The following is a description of a gene set: part of: Adipogenesis Brown and beige adipocytes convert chemical energy produced by the oxidation of fatty acids and glucose into heat, which is important for thermoregulation and control of body weight. Brown and beige adipocytes largely share the transcription program involved in adaptive non-shivering thermogenesis but develop from different lineages. Brown adipocytes share their precursor cells with skeletal muscle cells and develop in discrete, homogeneous brown adipose tissue depots. Beige adipocytes share their precursor cells with white adipocytes and develop in white adipose tissue in response to environmental stimuli, mainly exposure to cold, with an ability to revert to a white adipocyte-like phenotype. Development of beige adipocytes in white adipose tissue is known as white adipose tissue browning.<br><br>Brown and beige adipocytes have been characterized in most detail in rodents. In humans, brown adipose tissue was thought to regress after infancy, but was shown by multiple studies published after 2007 to persist in substantial deposits into adulthood adulthood. Molecular profiles that correspond to both brown and beige rodent adipocytes have been identified in human brown-designated adipose tissue, and therefore both brown and beige adipocytes are now thought to be conserved in humans.<br><br>The major protein marker of brown and beige adipocytes is Uncoupling protein 1 (UCP1). UCP1 resides at the inner mitochondrial membrane where it translocates protons (H+) from the intermembrane space into the mitochondrial matrix. UCP1 thus dissipates the proton-motive force to be used by ATP synthase, converting the energy released by the respiratory chain into heat. Brown adipose tissue is innervated by the sympathetic nervous system. Noradrenaline is secreted by sympathetic neurons when the central nervous system senses cold. Brown adipocytes possess adrenergic receptors on their surface that are activated by noradrenaline. Activated adrenergic receptors trigger a signaling cascade that induces lipolysis and activates UCP1.<br><br>Multiple transcription factors that regulate the thermogenic molecular signature are shared between brown and beige adipocytes, such as EBF2, PRDM16, ZNF516, and PPARGC1A. Master regulators of adipogenesis, such as PPARG and CEBPB, are shared between white, brown, and beige adipocytes.<br><br>Besides its role in thermoregulation, white adipose tissue browning is implicated in cancer-associated cachexia, a complex tissue-wasting syndrome characterized by inflammation, hypermetabolism, increased energy expenditure, and anorexia.<br><br>For review, please refer to Bartelt and Heeren 2014, Wang and Seale 2016, Ghaben and Scherer 2019, Cannon et al. 2020, Weber et al. 2022. Reactome Pathway: Transcriptional regulation of brown and beige adipocyte differentiation species: Homo sapiens, and this is the list of marker genes: MTA1, PPARGC1A, PPARGC1B, COX7A1, MBD3, ZNF423, RBBP7, HDAC2, SMAD1, RBBP4, PPARA, SMAD4, UCP1, NCOA1, DIO2, ELOVL3, BLNC1, BMP7, PRDM16, MTA3, RXRA, CIDEA, CHD3, EBF2, MTA2, PPARG (NCBI Gene Id 5468), HDAC1, CHD4, GATAD2B, GATAD2A, HNRNPU